The following is a description of a gene set: The presence of a supernumerary finger or toe (not a thumb or hallux) involving the third or fourth metacarpal/tarsal with associated osseous syndactyly. species: Homo sapiens Human Gene Set: HP_MESOAXIAL_POLYDACTYLY Mesoaxial polydactyly, and this is the list of marker genes: TOPORS, GJA5 (gap junction protein alpha 5), IFT27, FAM149B1, KIF7, LZTFL1, OFD1, TMEM231, TMEM216, MKKS, MAP3K20, FGFR2 (NCBI Gene Id 2263), RAB34 (NCBI Gene Id 83871), GJA8, TWIST1, KIAA0753, CPLANE1, GLI3, HOXD13, TCTN3, PDE6D, CHSY1, TFAP2B